Given this list of marker genes DBT, BCKDK, DLD, BCKDHB, BCKDHA, here is a description of the gene set: Branched-chain ketoacid dehydrogenase kinase deficiency species: Homo sapiens Human Gene Set: REACTOME_BRANCHED_CHAIN_KETOACID_DEHYDROGENASE_KINASE_DEFICIENCY